The following is a description of a gene set: Human Gene Set: GSE21033_CTRL_VS_POLYIC_STIM_DC_1H_DN from publication Olex AL, Hiltbold EM, Leng X, Fetrow JS (PMID 20682054) Genes down-regulated in bone marrow-derived dendritic cellstreated by poly(IC): 0h versus 1h. BACKGROUND: Dendritic cells (DC) play a central role in primary immune responses and become potent stimulators of the adaptive immune response after undergoing the critical process of maturation. Understanding the dynamics of DC maturation would provide key insights into this important process. Time course microarray experiments can provide unique insights into DC maturation dynamics. Replicate experiments are necessary to address the issues of experimental and biological variability. Statistical methods and averaging are often used to identify significant signals. Here a novel strategy for filtering of replicate time course microarray data, which identifies consistent signals between the replicates, is presented and applied to a DC time course microarray experiment. RESULTS: The temporal dynamics of DC maturation were studied by stimulating DC with poly(I:C) and following gene expression at 5 time points from 1 to 24 hours. The novel filtering strategy uses standard statistical and fold change techniques, along with the consistency of replicate temporal profiles, to identify those differentially expressed genes that were consistent in two biological replicate experiments. To address the issue of cluster reproducibility a consensus clustering method, which identifies clusters of genes whose expression varies consistently between replicates, was also developed and applied. Analysis of the resulting clusters revealed many known and novel characteristics of DC maturation, such as the up-regulation of specific immune response pathways. Intriguingly, more genes were down-regulated than up-regulated. Results identify a more comprehensive program of down-regulation, including many genes involved in protein synthesis, metabolism, and housekeeping needed for maintenance of cellular integrity and metabolism. CONCLUSIONS: The new filtering strategy emphasizes the importance of consistent and reproducible results when analyzing microarray data and utilizes consistency between replicate experiments as a criterion in both feature selection and clustering, without averaging or otherwise combining replicate data. Observation of a significant down-regulation program during DC maturation indicates that DC are preparing for cell death and provides a path to better understand the process. This new filtering strategy can be adapted for use in analyzing other large-scale time course data sets with replicates. studied in species Homo sapiens, and this is the list of marker genes: PIGA, REL, DOCK6, GDAP2, CPLANE2 (NCBI Gene Id 79363), PFKFB3 (6-phosphofructo-2-kinase/fructose-2,6-biphosphatase 3), GCM1, KCNN3, NFKBIB, SPTB, IL18, SFPQ, TEX13A, SOCS1 (suppressor of cytokine signaling 1), DUSP10, SPDEF, CA7, RTF2, TMEM39A, SERPINA2, ZFR2, YPEL5, NFKB1, CTRB2, PPARD, TRDMT1, RNF10, COQ7, PDLIM1, JUNB, CHRNA3, CTDP1, CMC2, OR1F2P, GJB5, REG1A, GSTA3, AGFG1, GLS, GATA2, CALCOCO1, CDKN2B, HSPA13, KHDC1L, APOBR, DDR2, DGCR5, CHMP1B, RAB3GAP1 (NCBI Gene Id 338380), VPS54, IL1R2, DHCR7 (NCBI Gene Id 6589), KCNMB1, CTRC, MORF4L2, SLC3A2, CLK1, SRSF3 (serine and arginine rich splicing factor 3), ZNF674, EIF4A1 (eukaryotic translation initiation factor 4A1), MARCHF5, ZNF587, ACSL5, RBMS1, NEUROD1, SDF4, RGS20, SNIP1, DCP1A, NFKB2, SLC38A2, SPTBN4, CD59, PORCN, POU4F3, THBS2, CSF2, ITCH, SORBS3, B3GAT1, GIMAP4, R3HDM4, CHPF2, SACS, MAGEA1, ECD, SERPIND1, SCARF1, POMP, HECA, ZC3H15, SIRT6, SLC15A1, SFSWAP, COQ2, SLC25A15, FGGY, ARIH1, LRIF1, USP32, CEBPB, TFF1, NEU3, NCLN, SQSTM1, RUSC2, TPM3, SLC27A2, DOP1A, BAZ1A, KDM6B, LMNA, PHLPP2, PPRC1, DESI1, AMMECR1 (AMMECR nuclear protein 1), ASPA, GPM6A, MKRN7P, NRG1, HPSE, SVEP1, AQP9, PKNOX2, TMUB2, THBS4, GRM6, RGS17, ASCC1, PPP1R11, VSX1, IDI2-AS1, LHX5 (NCBI Gene Id 64211), CRK, CDKL2, TPGS2, RIPPLY3 (NCBI Gene Id 53820), YBX3, TUBB3, MEX3C, GAS1, NCS1, KATNBL1, PHF10, ACVR1B, DYRK2, ARHGEF10, LRRC3, ANK1, TAF4, CD247, PI3, LTBP2, SYNJ1, FCGR2C, BTG3, H3-3B, PPP6C, FAM66D, ZYX, DYRK3, ZPR1, GRAMD2B, PITPNA, CENPT, PSPN, H1-4, AEN, RND2, NUP58, CHRM4, TRIP11, NTRK1, TCF7, USP7, CCDC177, BCAR3, MEIS3P1, ULBP2, CD5, AFDN-DT, PMFBP1, EIF2B2, ING3, CDV3, DOT1L, ITIH1, AZI2, DOCK9, FSD1, AKT3, MARCHF7, OR7A5, MAPKAPK2, ASH1L, PLEKHM1 (pleckstrin homology and RUN domain containing M1), MAP4K5, BZW1